Given this list of marker genes CNNM4, ROM1, TUB, ARL3, AHR (NCBI Gene Id 196), RHO, TTC8, NRL, CA4, SCAPER, CFAP418, IMPG2, HK1, RAB28, PRCD, CNGB3, ARL2BP, ERCC4, MAK, PDE6H, CNGB1, AIPL1, LRAT, RPGRIP1, AHI1, CDHR1, KLHL7, RP9, GNAT2, ARV1, KIAA1549, NR2E3, ARHGEF18, HGSNAT, NEK2, TLCD3B, USH2A, CC2D2A, OFD1, PITPNM3, CLRN1, CRX (cone-rod homeobox), IDH3B, DRAM2, PDE6A, RDH11, SEMA4A, OPN1MW, ARL6, RPE65, PROM1, LCA5, CRB1, CFAP410, CCDC28B (NCBI Gene Id 79140), GGCX, ABCA4, PRPF6, AGBL5, RLBP1 (retinaldehyde binding protein 1), PRPF8, CHM, SSBP1, COL18A1, POMGNT1, POC1B, GUCA1B, CACNA1F, EYS, MERTK (MER proto-oncogene, tyrosine kinase), MVK, SLC6A6, SAG, RBP3, SLC24A1 (NCBI Gene Id 9187), SLC7A14, CNGA1, KIZ, TULP1, PDE6B (NCBI Gene Id 5158), PDE6G, GUCA1A, BBS2, TTLL5, BEST1, BBS5, GUCY2D, ZNF408, REEP6, NMNAT1, RP1, ZNF513, FAM161A, UNC119, RGR, FSCN2, PRPF4, RAX2, PRPF3, HLA-A, RDH5 (retinol dehydrogenase 5), USP45, IMPG1, RP2, WDR19, IMPDH1, PCARE, CNGA3, ADAM9, FGF12, CACNA2D4, HARS1, IFT43, RP1L1 (RP1 like 1), ALMS1, RTTN, BBS1, BBS9, IFT140, IDH3A, NUS1, TRNT1, DHDDS, PRPH2, IFT172, SNRNP200, PRPF31, OPN1LW, SPATA7, MKS1, RPGR, FLVCR1, RIMS1, RDH12, DHX38, CERKL, IFT88, CLCC1, PDE6C, ATF6, TOPORS, here is a description of the gene set: Human Gene Set: HP_ATTENUATION_OF_RETINAL_BLOOD_VESSELS species: Homo sapiens Attenuation of retinal blood vessels